The following is a description of a gene set: ROS in COVID-19 endothelial dysfunction species: Homo sapiens Human Gene Set: WP_ROS_IN_COVID19_ENDOTHELIAL_DYSFUNCTION, and this is the list of marker genes: ICAM1, TNF, NFKB1, TNFRSF1A, IFNA1, NOX1, IFNAR1, ACE2